The following is a description of a gene set: species: Homo sapiens Human Gene Set: GOMF_COENZYME_A_DIPHOSPHATASE_ACTIVITY Catalysis of the reaction: an acyl-coenzyme A or its derivatives + H2O = adenosine 3',5'-bisphosphate + an acyl-4'-phosphopantetheine + 2 H+. This reaction can also use coenzyme A as a substrate., and this is the list of marker genes: FITM1, NUDT19, NUDT8, NUDT7, FITM2